Given this list of marker genes SUCLA2, MYPN, TPM2, TTN, MTRFR, ABCA1, SLC52A3, KBTBD13, POLG, GLE1, TWNK, FKRP, CFL2, SLC25A4, ADCY6, DMPK, BIN1, ADGRG1, EBF3, SHMT2, NEB, CRPPA, SOST, KLHL41, FKTN, SLC12A6, SRPX2, TK2, PI4KA (NCBI Gene Id 5297), TPM3, LMOD3, RYR1, YME1L1, POMT1, MPZ, KLHL40 (NCBI Gene Id 131377), SPEG, SCO2, ACTA1, CRYAB, CNTNAP1, VCP, RRM2B, POLG2, here is a description of the gene set: Human Gene Set: HP_FACIAL_DIPLEGIA Facial diplegia refers to bilateral facial palsy (bilateral facial palsy is much rarer than unilateral facial palsy). Facial diplegia species: Homo sapiens